The following is a description of a gene set: species: Mus musculus A process in which a protein is transported to, or maintained, in a location within a cell-cell junction. Mouse Gene Set: GOBP_PROTEIN_LOCALIZATION_TO_CELL_CELL_JUNCTION, and this is the list of marker genes: Dsg3, Dsg2, Tjp1 (NCBI Gene Id 381892), Actg1, Mpp7, Ildr1, Mapk9, Mapk8, Pecam1 (NCBI Gene Id 97748), Dsp, Vcl, Lsr, Abcb1a, Actn4, Tjp3, Cdh5, F11r, Pak2, Jak1, Zdhhc7, Scrib, Tjp2, Cgnl1, Arhgef18 (Rho/Rac guanine nucleotide exchange factor 18), Flna, Ctnnd1, Dlg5, Actb, Hepacam